The following is a description of a gene set: An abnormality of the larynx. Human Gene Set: HP_ABNORMALITY_OF_THE_LARYNX Abnormality of the larynx species: Homo sapiens, and this is the list of marker genes: NOTCH2NLC, RSPO1, KCNMA1, RPL10, FGFR2, PRTN3, UNC13A, GLI3, TCTN3, HIRA, HNRNPA1, DAO (D-amino acid oxidase), COL12A1, OPTN, MSH2, FREM2, FLII, ASAH1, PLP1, MGP, MYMK (myomaker, myoblast fusion factor), MSH6, MAP3K7, CREBBP, SF3B4, DEAF1, ARSL, PRRX1, PRPH, HLA-DPB1, VAPB, SOD1, PTPN22, DHCR7, DYNC2I2, EFL1, MYMX, UBQLN2, HNRNPR, LRP4, CTLA4, CHEK2, LTBP4, PSAP, TBK1, SNIP1, SLC26A2, KRT14, DTYMK, FBXW7, MDM2, IQSEC2 (IQ motif and Sec7 domain ArfGEF 2), POLR3A, HLA-DPA1, HDAC4, LBR, EPCAM (NCBI Gene Id 4275), NEFH, RFX7, INTU, DYNC2H1, RAI1, VCP, PRNP, WDR35, RAF1, PTH1R, KAT6A, SOX4, TREM2, NIN, ERBB4, PHIP, TARDBP, GLT8D1, FIG4, DYNC2I1 (dynein 2 intermediate chain 1), ZBTB7A, TBX4, POR, HSPG2, ANO3, FOXE1, CAT, XPNPEP2, LAMA3, SCN4A, C2CD3, ZIC3, MATR3, TGFBR2, LONP1, UFC1, SOX9, PLG (NCBI Gene Id 90749), GBA1, MKS1, SMAD4, LAMC2, KIF7, WRN, HOXD13, GIPC1, NRCAM, APC, PORCN, CTSK, TAF15, EP300, NLRP1, ARVCF, ANG, CILK1, TAF1, HAAO, DDRGK1, SIAH1, GP1BB, PCNT, ROBO1, CACNA1C, KRT5, RTL1, SETBP1, COMT, RILPL1, SEMA3E, DCTN1, GLE1 (GLE1 RNA export mediator), CHD7, PMS1, NFIX, BTD, LAMB3, FANCB, FRAS1, SMAD2, SERPING1, DDX3X, FERMT1, SQSTM1, ATP6V1E1, ATXN2, EXTL3, AMER1, CHMP2B, PFN1, PON2, ZNF699, PIK3CA, KRAS, ASXL3, HS3ST6, FLNB, EDN1, PMS2 (NCBI Gene Id 91271), PPM1D, ADAMTSL2, SRPX2, LMNA, H3-3B, CHCHD10, PUF60, FLNA, SCARF2, CDKN2A, CENPE, TONSL, SEC24C, CFAP410, MT-CYB, JMJD1C, IFT80, H3-3A, PON1, PON3, BRF1, TBX3, CASR, PKDCC, FGFR3, PRMT7, RALGAPA1, LTBP3, GRIN2A, KAT6B, WNT3, VPS13B, CCNF, ADARB1, AFF4, RREB1, PPARGC1A, MID1, FGF10, IDH1, TP53, SYT1, EIF4A3, AHDC1, GRIP1, KIF22, HYLS1, DYNC2LI1, SATB2, MEIS2, LRP12, EPHB4, ANXA11, RSPO2, UFD1, FUS, CAPN15, MLH1, POLR1A, NEK1, SPTBN1, GMNN, UBE3B, TBX1, ORC6, TSPYL1, KANSL1, DLK1, GALC, GABRG2, MEG3